The following is a description of a gene set: Mouse Gene Set: CUI_NEUTROPHIL_IL18_RESPONSE_DN Cytokines mediate cell-cell communication in the immune system and represent important therapeutic targets. A myriad of studies have highlighted their central role in immune function, yet we lack a global view of the cellular responses of each immune cell type to each cytokine. To address this gap, the authors created the Immune Dictionary, a compendium of single-cell transcriptomic profiles of more than 17 immune cell types in response to each of 86 cytokines (>1,400 cytokine-cell type combinations) in mouse lymph nodes in vivo. A cytokine-centric view of the dictionary revealed that most cytokines induce highly cell-type-specific responses. For example, the inflammatory cytokine interleukin-1β induces distinct gene programmes in almost every cell type. A cell-type-centric view of the dictionary identified more than 66 cytokine-driven cellular polarization states across immune cell types, including previously uncharacterized states such as an interleukin-18-induced polyfunctional natural killer cell state. Genes negatively differentially expressed in cell type: Neutrophil upon treatment with cytokine: IL-18 in mouse lymph nodes in vivo. species: Mus musculus from publication Cui A, Huang T, Li S, Ma A, Pérez JL, Sander C, Keskin DB, Wu CJ, Fraenkel E, Hacohen N (PMID 38057668), and this is the list of marker genes: Mrpl33, Fos, Taldo1, Cotl1, Mmp9, Stk17b, Il17ra (NCBI Gene Id 16172)